The following is a description of a gene set: Mouse Gene Set: GOBP_OLIGODENDROCYTE_DIFFERENTIATION The process in which a relatively unspecialized cell acquires the specialized features of an oligodendrocyte. An oligodendrocyte is a type of glial cell involved in myelinating the axons of neurons in the central nervous system. species: Mus musculus, and this is the list of marker genes: 9630013A20Rik, Wdr1 (WD repeat domain 1), Bnip3, Nrg1, Eif2b2, Enpp1, Hes1, Cntn2, Il33, B4galt6, Id2 (inhibitor of DNA binding 2), Ckap5 (NCBI Gene Id 97044), Nlgn3, Enpp2, Zfp365, Hdac11, Tppp, Fa2h, Nkx6-1, Dlx2, Suz12 (SUZ12 polycomb repressive complex 2 subunit), Olig2, Nkx2-1, Kcnj10, Dicer1, Nkx2-2, Sox13, Sox8 (SRY (sex determining region Y)-box 8), Sox11, Fgfr3, Il34, Neurod4, Clcn2, Mir219a-2, Drd3, Omg, Tmem98, Hdac1, Wasf3, Qki, Ulk4, Hes5, Nfix, B4galt5, Ptprz1, Pax6, Tenm4, Ptprj, Nkx2-2os, Ascl1, Tlr2, Sox9, Mecp2, Sirt2, Dusp10, Dag1, Pparg, Ntrk2, Mobp, Tnfrsf1b, Otx2 (NCBI Gene Id 218991), Lyn, Gli3, Eif2b4, Plp1, Slc45a3, Dusp15, Gsx2, Mios, Nkx6-2, Cntnap1, Cnp, Gpr17, Abca2, Prdm8, Mal, Tspan2, Aspa, Nsun5, Prmt5 (protein arginine N-methyltransferase 5), Gstp1, Med12, Sox5, Ccdc39, Sox10, Clu, Mtor, Daam2, Ercc2, Vtn, Myrf (myelin regulatory factor), Id4, Opalin, Zfp488, Exoc4, Trp73, Trpc4, Bmp4, Slc8a3, Rheb (NCBI Gene Id 19744), Mir219a-1, Mdk, Grk2, Hdac2, Cntn1, Gpm6b, Ctnnb1, Sox1, Mir23a, Shh, Lingo1, Sox6, Cxcr4, Ptpra, Olig1, Csk, Tgfb1, Lpar1, Notch1, Ptn, Eed (embryonic ectoderm development), Tnfrsf21 (tumor necrosis factor receptor superfamily, member 21), Nf1, Pten, Cdk5, Eif2b3, Eif2b5, Erbb2, Ncstn, Dlx1, Cntnap2, Eif2b1, Tcf7l2 (transcription factor 7 like 2, T cell specific, HMG box), Cdkn2c (cyclin dependent kinase inhibitor 2C), Mag, Bok